The following is a description of a gene set: Goals/objectives: to identify various gene expression in B cell subsets derived from human PBMC and cord blood from publication Suryani S, Fulcher DA, Santner-Nanan B, Nanan R, Wong M, Shaw PJ, Gibson J, Williams A, Tangye SG (PMID 19965666) Human Gene Set: GSE17186_CD21LOW_VS_CD21HIGH_TRANSITIONAL_BCELL_CORD_BLOOD_DN Genes down-regulated in transitional B lymphocytes from cord blood: CR2 low versus CR2 high. species: Homo sapiens, and this is the list of marker genes: JADE2 (jade family PHD finger 2), XRCC1, ETHE1, MXD4, TECR, TMEM223, GRPEL2, DHODH, RITA1, SH3GLB2, ZNF239, UBL3, EFCAB2, FANCF, ZNF317, COX11, STEEP1 (STING1 ER exit protein 1), STOML1, ASB3, C9orf85, RFK, TACSTD2, FBXO8, C2orf42 (NCBI Gene Id 54980), SUSD3, IRF2BPL, BCL3, GUCD1, HEATR1, EHD1, ALDH2, ELK3, KCNG1, EZR, PPCS (phosphopantothenoylcysteine synthetase), ZSWIM3, CLUAP1, MTG1, SH3KBP1, ZBTB25, SLAIN1, PQBP1, JAK1, NAE1, RP9, ABHD14B, ADD1, PCMTD2, CFAP96, SLC16A7, ADD3, TCF3, NCK1 (NCBI Gene Id 4690), WARS1, MAP2K1, CCDC71L, SYK, BCDIN3D, CIB1, DHRS7B, SERINC3, POLR3H, GPN3, MDN1, BMAL1, BCL10, PMS2, PDCD10, RFLNB, CMTM7, SIPA1L2, YEATS4, OVGP1, NAPSA, B3GNT8, CD200, YPEL3 (NCBI Gene Id 83719), PITPNM2, MON2, ESCO1, PHF1, IRGQ, GPAM, STAT4, HDAC7, KCNA3, RPL37A, ABRAXAS1, EZH1, RTTN, TRAPPC5, PPAT, CEP97, CAPN5, SMPD1, PDCD4, GPD1L, BCAR3, HHEX, MRGBP, CERS4, KTN1, AREL1, CERK, HOPX, GEMIN4, TASL, KCNK5, UTP14A (NCBI Gene Id 95977), SP110, PHYKPL, IGKC, TRMT1, PRKCB, PHGDH, XRN2, CAMK2D, PLCL2, DFFA, ESYT1, TFAM, PIAS4, NEU1, MDP1, HADH, USP11, MRGPRE, LDB1, BTD, MTCP1, MTARC2 (NCBI Gene Id 96692), MGST2, SCAF11, METTL23, SNORD104 (NCBI Gene Id 692227), CNPY4, SERTAD1, SLC2A1, STAP1, XRCC5, RBM43, CNOT6L, ZFP14, PARP16, SNRPG (NCBI Gene Id 6637), TNK2, ACTR3B, ZNF512, CDPF1, TCF12, PRPS2, HES5, PTPN1, RAB2B, MAP7, POU2F2, TUT4, HDAC5, PDHA1, ICAM2, VPS54, TRIM65, TLR7 (NCBI Gene Id 51284), RETREG1, MPP1, RCSD1, GSTT2, LTA (lymphotoxin alpha), SIDT1, MTERF2, CSK, CD40, RNF144A, MYO7A, MTNAP1, MYNN, OARD1, PSD4, SZT2, RECQL5 (NCBI Gene Id 9400), EXOSC10, RPL36A, CD164, NFATC1, WDR33, NADSYN1, TK2, CKAP4, SMARCD2, UBTF (NCBI Gene Id 7343), ITGB3, IL10RB, PANX1, PCED1B, DENND5B, NSMCE1, LY9, SPTAN1, ZBTB1, MINDY2